Given this list of marker genes Edem3, Edem2, Tshr, Rplp0, Nppc, F7, Slc5a5, Man1a, here is a description of the gene set: Mouse Gene Set: GOBP_RESPONSE_TO_GLYCOPROTEIN species: Mus musculus Any process that results in a change in state or activity of a cell or an organism (in terms of movement, secretion, enzyme production, gene expression, etc.) as a result of a glycoprotein stimulus.